The following is a description of a gene set: Human Gene Set: GSE2197_CPG_DNA_VS_UNTREATED_IN_DC_UP from publication Stetson DB, Medzhitov R (PMID 16413926) Bone marrow-derived dendritic cells were left untreated or stimulated with lipid-transfected double-stranded DNA or CpG oligonucleotides for four hours before harvesting. species: Homo sapiens Genes up-regulated in comparison of dendritic cells (DC) treated with CpG DNA (TLR9 agonist) DNA versus the untreated cells., and this is the list of marker genes: HDC, IFIH1, SLC15A3, TLK2, GSAP, PIM2, HCLS1, PMEPA1, P2RY14, HAS1, USP12, ELL2, VANGL1, PTPN1, RCL1, AZI2, MTFR2, AFP, NUP58, BLOC1S4, KAZN, MAFF, MORC1, ACP2, RASGRP1, RHBDF2, OGFR, MOV10, ENPP4, POGZ, NAALAD2, SAMSN1, TRIOBP, MSX2, SNN, STAT1, EHD1, COPS5, TMEM184B, DYRK2, KPNA4, TNIP1, PPP1CB, CCDC187, PFDN4, PSMB8, PTPN12, IL36A, TAPBP, FAM20B, ZMAT2, PCMT1, CYP51A1, PTPRE, TMEM140, TSHZ1, PRELID3B, DGAT2, RHOC, RAB22A, RIOX2, SLC20A1, TMEM171, SLC12A4, UBE2L3 (NCBI Gene Id 7332), SAV1, TMEM178A, CCL22 (C-C motif chemokine ligand 22), GTF2A1, F2, DUSP1, AFG2B, MDM2, CASP7, BCL2A1, PSMD1, RRS1, IL10, RAB20, FSCN1, LAD1, LACTBL1, TREM1, LYSMD1, SSR3, ILRUN, JPT1, RASA4, ARID5A, SRXN1, GPHN (NCBI Gene Id 57566), MS4A7, MANF, WBP2, GGPS1, IFITM10, TGM5, CAMK2D, VASP, BOC, KDM6B, FAM241A, AGTRAP, HSPA5, MYO10, ASB11, EIF2S1, GDF11, HSD17B12, IL15RA, SMNDC1, PSMD14, USP42, XYLT2, C11orf24, CCL1, SFPQ, UTP18, ACOT9, ACP3, PTGDS, MITF, PSMA2, ZC3HAV1, SEC24D, LARP1, NPPA, PELI1, SERPING1, UBE2A, HBEGF, CBLN4, EPHA4, CAPZA2, ITGAL, RRP9, F10, PSMA3, SELENOW, IDI1, PRDX5, TSC22D1, PPP1R15B, KLHL4, BDNF, UBE2F, APPBP2, RNF214, TSPAN3, TENT4A, SNRPA1, BTNL2, POLR2C, IRF1, TPBG, ST3GAL1, CD69, TOX4, VNN2, YBX3, NUPR1, RARS1, CAV2, DTX2, ARMH4, BLNK, RAB21, HARS1, TBK1, AP3M2, STAP1, C4orf54, PDE6B, DNAJC13 (DnaJ heat shock protein family (Hsp40) member C13), NR4A3, NLRP3, PILRB, STXBP1, SLC34A3, CCNJ, CCL19, HP, TCAF2, CHMP4B, TGM2, GMPPB, ADPRH, RNF114, HSH2D, LRCH3, MIER2, ARHGAP28, YTHDF1, SCN5A, THBS4, ICAM1, SLFN13, BCO2, TAB2, BEND3